Given this list of marker genes Stxbp2, Cadps (Ca2+-dependent secretion activator), Snap25, P2rx7, Unc13b, Rims1, Stxbp3, Rab3a, Syt10, Stxbp1 (NCBI Gene Id 98927), here is a description of the gene set: Mouse Gene Set: GOBP_PRESYNAPTIC_DENSE_CORE_VESICLE_EXOCYTOSIS studied in species Mus musculus The secretion of molecules (e.g. neuropeptides and neuromodulators such as serotonin and dopamine) contained within a membrane-bounced dense in response to increased presynaptic cytosolic calcium levels.